The following is a description of a gene set: studied in species Homo sapiens Degeneration (wear and tear) of articular cartilage, i.e., of the joint surface. Joint degeneration may be accompanied by osteophytes (bone overgrowth), narrowing of the joint space, regions of sclerosis at the joint surface, or joint deformity. Human Gene Set: HP_OSTEOARTHRITIS Osteoarthritis, and this is the list of marker genes: COL2A1, TRAPPC2, SMAD3, COL5A1, COL11A1, PHEX, FGFR3, DDRGK1, COL9A2, PTPN22, GDF5, CANT1, TRPS1, TRPV4, PRG4, AEBP1, CLCN7, KIF22, IL2RA, MATN3, AIP, ZNF687, TNFRSF11B, ZMPSTE24, STT3A, GPR101, GNAS, LMNA, HPGD, COMP, UFSP2 (NCBI Gene Id 55325), ANKH, MMP13, COL9A1, PTPN2, NGF, HGD, COL5A2, STAT4, SLC40A1, EMILIN1, F9, SLC26A2, COL1A1, F8, TGFB3, IL2RB, SCARB2, FBN1, GBA1, GHR, COL11A2, ANKRD55, ATP7B, SMAD2, CD247, COL3A1, ASPN, ACAN, MEFV, FRZB, CCN6, HLA-B, COL9A3, BMP4